Given this list of marker genes Arhgef15, Plce1, Fgd1, Dock7, Dennd4a, Plekhg5, Rapgef6, Rasgrp4, Arhgef9, Spata13, Dock1, Cyth2, Arhgef10l, Sec61b, Fgd6, Mcf2, Gdpgp1, Plekhg1, Dennd3, Dennd2d, Arhgef38, Sbf1, Eef1b2, Dock5, Ccdc88c, Smcr8, Cyth1, Obscn (obscurin, cytoskeletal calmodulin and titin-interacting RhoGEF), Dock9, Arhgef39, Dock6, Rab3ip, Iqsec1, Net1, Rasgrp3, Vps9d1, Eif2b3, Lamtor5, Prex1, Dnmbp, Arhgef7, Rasgrp2, Eif2b5, Arhgef18, Arhgef33, Rcc2, Sbf2, Rabgef1, Arhgef25, Ric1, Rcc1, Eif2b1, Dock8, Arhgef4, Thg1l, Madd, Fgd2 (NCBI Gene Id 26382), Rasgrf1, Arhgef17, Vav3, Plcd4, Dennd1c (DENN domain containing 1C), Sos1, Dennd1b (DENN domain containing 1B), Rab3gap1, Rin3 (Ras and Rab interactor 3), Preb, Rapgef2, Rapgefl1, Dennd2a, Rab3gap2, Rinl, Dock11, Itsn2, Lamtor1 (late endosomal/lysosomal adaptor, MAPK and MTOR activator 1), Arfgef1, Egf, Ccz1, Abr, Bcar3, Plekhg3, Dennd2c, Arfgef3, Akap13, Lamtor4, Slc38a9, Fgd3, Cyth4, Cyth3, Pcp2, Rapgef1, Farp1, Rin2, Rap1a (NCBI Gene Id 99734), Dennd2b, Eef1d, Mycbp2, Dis3 (NCBI Gene Id 72662), Arhgef28 (NCBI Gene Id 77910), Ralgps2, Arhgef11, Wdr41, Eif2b4, Trio, Mcf2l, Ankrd27, Rgl3, Dennd1a, Rcc1l, Nucb1, Psd, Rapgef4, Frmd7, Psd3, Ect2, Dennd6a, Gbf1, Arhgef37, Kndc1, Ralgps1, Vav2, Ric8a, Eps8l3, Rabif, Rpgr, Elmo1, Hps4, Rasgrp1, Rasgef1c, Arhgef5, Dennd11, Sh2d3c, Arhgef16, Dennd4b, Ralgds, Lamtor2, Rapgef3, Fbxo8, Sh3bp5, Ccdc88a, Psd4, Vav1, Kalrn, Arfgef2, Chrm4, Gapvd1, Dennd5b, Psd2, Rgl2, Sergef, Fgd4, Rasgrf2, Dock10, Dock4, Als2cl, Tiam2, Plcg1, Iqsec2, Iqsec3, Plekhg2, Gripap1, Eif2b2, Eps8l1, Arhgef3, Hps1, Rap1gds1, Nucb2, Eps8l2, Rgl1, Dennd10 (NCBI Gene Id 67894), Ngef, Plekhg6 (NCBI Gene Id 213522), Ranbp10, Arhgef19, C9orf72, Lamtor3, Rasgef1a, Dennd4c, Arhgef1, Als2, Prex2, Farp2, Arhgef12, Rab3il1, Dock2, Tagap, Sh3bp5l, Rasgef1b, Rgp1, Bcr, Fgd5, Arhgef2, Dennd5a, Rin1, Dock3, Rapgef5, Tbc1d10a, Rangrf, Deptor, Ric8b, Dennd6b (DENN domain containing 6B), Arhgef40, Sos2, Arhgef6, Itsn1, Mon1a, Arhgef10, Tiam1, here is a description of the gene set: Mouse Gene Set: GOMF_GUANYL_NUCLEOTIDE_EXCHANGE_FACTOR_ACTIVITY Stimulates the exchange of GDP to GTP on a signaling GTPase, changing its conformation to its active form. Guanine nucleotide exchange factors (GEFs) act by stimulating the release of guanosine diphosphate (GDP) to allow binding of guanosine triphosphate (GTP), which is more abundant in the cell under normal cellular physiological conditions. studied in species Mus musculus